Given this list of marker genes BAP1, DKK1, FGFR3 (NCBI Gene Id 55546), NF2, PDGFB, SUFU, AKT1, PIK3CA, SMARCB1, TERT (NCBI Gene Id 7015), TRAF7, SMO (smoothened, frizzled class receptor), TNFRSF11A, SMARCE1, here is a description of the gene set: Human Gene Set: HP_BRAIN_STEM_COMPRESSION Brain stem compression species: Homo sapiens